Given this list of marker genes CREBBP, RPS6KA5, PAK1, KRAS, PRKACA, ICAM3, EP300, RELA, PAK3, RELB, LYN, ICAM2, PRKACG, NFKB1, PAK2, HRAS, CD209, FYN, PRKACB, RAF1, NRAS, here is a description of the gene set: CD209 (also called as DC-SIGN (DC-specific intracellular adhesion molecule-3-grabbing non-integrin)) is a type II transmembrane C-type lectin receptor preferentially expressed on dendritic cells (DCs). CD209 functions as a pattern recognition receptor (PRR) that recognises several microorganisms and pathogens, contributing to generation of pathogen-tailored immune responses (Gringhuis & Geijtenbeek 2010, den Dunnen et al. 2009, Svajger et al. 2010). CD209 interacts with different mannose-expressing pathogens such as Mycobacterium tuberculosis and HIV-1. It also acts as an adhesion receptor that interacts with ICAM2 (intracellular adhesion molecule-2) on endothelial cells and ICAM3 on T cells. CD209 functions not only as an independent PRR, but is also implicated in the modulation of Toll-like receptor (TLR) signaling at the level of the transcription factor NF-kB. CLEC7A (Dectin-1) and CD209 (DC-SIGN) signalling modulates Toll-like receptor (TLR) signalling through the kinase RAF1 that is independent of the SYK pathway but integrated with it at the level of NF-kB activation. The activation of RAF1 by CLEC7A or CD209 does not lead to activation of extracellular signal-regulated kinase 1 (ERK1)/2 or Mitogen-activated protein kinase kinase 1 (MEK1)/2 but leads to the phosphorylation and subsequent acetylation of RELA (p65). RELA phosphorylated on S276 not only positively regulates the activity of p65 through acetylation of p65, but also represses RELB activity by sequestering active RELB into inactive p65-RELB dimers that do not bind DNA. RAF1-dependent signaling pathway is crucial in dectin-1 mediated immunity as it modulates both the canonical (promoting p65 phosphorylation and acetylation) and non-canonical (forming inactive p65-RELB dimers) NK-kB activation. part of: C-type lectin receptors (CLRs) species: Homo sapiens Reactome Pathway: CD209 (DC-SIGN) signaling